The following is a description of a gene set: Any process that results in a change in state or activity of a cell or an organism (in terms of movement, secretion, enzyme production, gene expression, etc.) as a result of a prostagladin stimulus. Mouse Gene Set: GOBP_RESPONSE_TO_PROSTAGLANDIN species: Mus musculus, and this is the list of marker genes: Edn1, Ptger2, P2ry6, Ppp1r9b, Ccl19-ps6, Ptgfr, Adcy6, Ccl21b, Prkce, Scn11a, Ptger4, Ccl19 (NCBI Gene Id 24047), Tnc, Acaca, Aanat, Hmgcs2, Ccl21a, Akr1c18, Ccl19-ps4, Ccl19-ps1, Akap8, Gnai1, Cyp27b1, Ccl19-ps3, Akt1, Ccl19-ps5, Ptgdr, Sfrp1 (NCBI Gene Id 72362), Pax6, Gnas, P2ry4, Prkaa2, Ccr7, A2m, Ptger1, Oxt, Ccl21d, Tgfbr3, Tnfsf4, Yy1, Prkaa1, Ccl21f, Ccl21e